The following is a description of a gene set: studied in species Homo sapiens from publication Jeffrey KL, Brummer T, Rolph MS, Liu SM, Callejas NA, Grumont RJ, Gillieron C, Mackay F, Grey S, Camps M, Rommel C, Gerondakis SD, Mackay CR (PMID 16474395) Genes down-regulated in comparison of mast cells versus NK cells. In the present study we used Affymetrix oligonucleotide microarrays to produce gene transcription profiles for the major leukocyte types in humans. This comprehensive dataset enabled us to not only establish which genes were expressed in each leukocyte type, but also which genes were expressed in each subset after activation. The used of a comprehensive dataset of gene profiles from all the major human leukocyte subsets enabled a novel and powerful means for identification of genes associated with single leukocyte subsets, or different immune paradigms. Human Gene Set: GSE3982_MAST_CELL_VS_NKCELL_DN, and this is the list of marker genes: MKRN1, BARD1 (NCBI Gene Id 580), LILRB2, IRF8, TBC1D22A, SDAD1, UNC5C, SPOCK2, OR2H1, PPARA, HMGB3P30, CD72, ITPKB, ATRNL1, PIWIL2, PRMT2, GALNS, BCKDHA, VPS11, SPSB3, APBA3, PNRC1, KIR2DL3, PRSS16, GAD2, SERPINA3, ASXL1, CSK, SIGIRR (single Ig and TIR domain containing), KCNA3, MAP1S, CYTH1, CDH18, SIDT1, C21orf91, DIDO1, RTP4, CAPN2, FBXO40, LTB4R2, RBM12B, CAMKMT, RPP25, LRRTM4, KRT85, TMC5 (NCBI Gene Id 79838), CCDC186 (NCBI Gene Id 55088), PIGL, OAS3, GNL1, ZNF394, EVL, FAM193B (family with sequence similarity 193 member B), SNX6 (NCBI Gene Id 58533), DOK2, NPHS2, PVRIG, REEP1, CPN2, F2R, ARHGAP24, ECM2, GRIK2, TSPAN1, PMCH, MFAP5, GPM6B, APLP1, TOR1A, REG1CP, GABRD, SECTM1, SPTBN5, POLR1G, NDRG3, MYH1, COL14A1, LAIR2, UNC5B, DNAH2, CDS2, SEMA6C, UBQLN3, HK3, SUN2, UBIAD1, ZNF185, CADPS2, SNIP1, TXK, CHST4, FYN, ADIPOR2, ARHGAP32 (NCBI Gene Id 9743), SEC14L5, MAP2K7, ALPL (alkaline phosphatase, biomineralization associated), GSTA3, ARFGAP1, KLRB1, PLSCR3, ANKRD11, ARAP1, SYNGR1, PDE11A, SKAP1, ERAL1, KCNC1, MUTYH, CACNA2D2, ETV4, ARHGEF15, STN1, SH2D1A, TAC1, CCNJL, RNF44, MAEA, SIT1, CFLAR, CD79B, UCP2, IL27RA, CHTOP, DOLPP1, RAMP1, NRG1, GINS4, CTSW, GCH1, CPSF4, SCTR, ISG20, RAB36, HLA-F, LPAL2, MYOZ1, AKR1C1, HDAC9, SYNE2, USP20, CYP1A2, TLE2, YPEL1, L2HGDH (NCBI Gene Id 79944), NELL1, ARMCX2, CYP2C19, PPP3CC, ZNF385D, AGAP2, STOM, GIMAP6, CCND3, SEPTIN6, TRIM25, RORA, METRN, YIPF1, STAB2, MICAL2, NCOA1, VCL, ADAM2, PRR5L, IFITM1, AFDN-DT, FAM53B, SNHG20, LIPE, KIR2DL1 (killer cell immunoglobulin like receptor, two Ig domains and long cytoplasmic tail 1), RUSC1 (NCBI Gene Id 23623), EIF2AK1, PPP1R13L, ABCG2, CEMIP, ACVR2A, TRAF1, CUZD1, GALT, PGGHG, CD300A, ERN1, MX2, NUAK1, CLEC2B, NKG7, CLIC2, TMEM204, STAT4, DENND3, SMPD3, PIK3C2G, IMPDH1, NHLH2, ITK, PML, SUPT3H, IL18RAP